The following is a description of a gene set: species: Homo sapiens Enables the transfer of a specific substance or related group of substances from one side of a membrane to the other, up the solute's concentration gradient. The transporter binds the solute and undergoes a series of conformational changes. Transport works equally well in either direction. Human Gene Set: GOMF_ACTIVE_TRANSMEMBRANE_TRANSPORTER_ACTIVITY, and this is the list of marker genes: ABCC12, SLC39A10, SLC12A2, COX4I1, SLCO4A1 (NCBI Gene Id 51737), ABCA3, SLC30A4, ABCC3, CLCN7, SLC8A2, ATP6V1F, MT-ND1, SLCO1C1, SLC29A4, SLC6A6, SLC36A3, SLC9A9, SLC4A8, SLC30A1, SLC25A31, SLC6A15, SLC4A1, ATP6V0D2, SLCO4C1, SLC35B2, CYBRD1, SLC30A9, SLC38A7, SLC8A1, ABCG4, SLC45A2, NDUFS5, SLC25A25, ATP2A1, SLC9B1P1, SLC35A5, SLC10A1, SLC9C2, SLC9B1, TCIRG1, SLC16A13, ATP2A2, LETM1, SLC7A5, NDUFB8, SLC36A1, SLC16A2, SLC18A3, SLC16A4, SLC16A9, SLC18A1, COX7A2L, UQCRC1, SLCO6A1, ABCD2, NDUFA2, MT-ND5, NDUFC1, XPR1, SLC7A11, ABCC5, ATP6V1E2, SLC6A5, SLC45A4, SLC46A2, SLC35A3, ABCC11 (ATP binding cassette subfamily C member 11), SLC17A2, SLC5A10, SLC25A30, SURF1, ATP6V1C2, SLC1A7, TAP1, ATP6V1G1, SLC13A1, SLC29A1, NDUFB1, ABCB11, ABCA4, ABCG1, SLC41A3, SLC25A26, SLC36A2, SLC22A1, SLC35E2A, MT-CO1, SLC4A11, SLC45A3, NDUFV3 (NADH:ubiquinone oxidoreductase subunit V3), UQCRFS1P1 (NCBI Gene Id 7387), SLC15A5, SLC6A18, SLC22A9, ATP6V1G2, SLC7A6, SLC13A3, SLCO1B3, ABCC9, SLC25A21 (solute carrier family 25 member 21), SLC30A5, SLC25A14, SLC20A2, SLC9A6, SLC17A9, SLC25A24, SLC35E2B, SLC25A13, SLC11A2, NDUFA6, SLC7A9, NDUFA8, NDUFS6, SLC35E3, SLC38A3, ABCC10, MT-CO2, SLC4A5, SLC17A7, ATP1A2, SLC6A7, SLC5A8, ABCC4 (ATP binding cassette subfamily C member 4 (PEL blood group)), SLCO2A1, SLC22A7, COX7A1, NDUFV2, TOMM20, SLC39A6, SLC6A13, SLC35C1, ATP2B3, NDUFC2, SLC6A1, ANKH, MFSD2B, SLCO1B3-SLCO1B7, MFSD2A, NDUFB6, CDH17, NDUFB5, SLC25A1, SLC25A11, NDUFA3, TMEM165, TMEM94, ABCB6, ATP6V0C, ATP1A4, SLC22A11, SLC35E1, NDUFB10 (NADH:ubiquinone oxidoreductase subunit B10), ATP2C1, SLC12A6, SLC13A4, SLC1A3 (NCBI Gene Id 6507), CLCN4, SLC6A14, ATP6V0E1, TAP2, ATP6V0A4, SLC17A5, ATP6V0B, MFSD12, SLC26A4, SLC26A2, ABCC8, SLC6A4, SLC25A6, ABCD4, ATP4A, SLC5A6, CYB561A3, SLC17A3, ABCA9, NDUFS1, SLC44A1, SLC13A2, SLC30A8, NDUFA12, SLC10A6, SLC25A4 (solute carrier family 25 member 4), NDUFS8, SLC1A1, COX7B, SLC9A2, SLC38A5, CLCN6, ATP7B, ABCG5, SLC47A2 (NCBI Gene Id 146802), SLC12A9, SLC39A12, SLC35A1, MT-ND6, SLC4A10, SLC9C1, NDUFS7, ATP2B2 (ATPase plasma membrane Ca2+ transporting 2), SLC35A2, SLC16A3, SLC34A1, SLC10A2, ATP6V0D1, SLC10A5, CFTR, SLC5A5, CLCN5, SLC37A3, ABCB10, ATP6V1A, ABCC2, SLC24A2, SLC6A11, SLC28A3, SLC37A4, ABCB4, SLC15A3, SLC6A19, SLC9A5, ATP12A, SLC24A5 (solute carrier family 24 member 5), SLC5A9, SLC5A7, ATP13A2, NNT, SLC38A2, SLC22A4, SLC5A12, ABCA10, UCP2, ATP6V1D, SLC2A9, SLC26A11, ABCA7, SLC25A18, ATP6V1C1, MCU, MTCO2P12, SLC25A22, ATP8A1, SLC11A1, NDUFA9, SLC17A4, KCNJ11, MT-ND4L, ABCB9, NDUFB4, SLC26A1, SLC32A1, NDUFB7, SLC2A10, SLC15A1, SLC6A16, SLC5A4, SLC6A12, SLC25A17, SLC46A1, SLC1A6, RALBP1, SLCO1B7, SLC22A6, SLC16A12, SLC1A4, NDUFA10, ATP6V1G3, SLC17A6, SLC30A10, SLC16A10, SLC22A2, ABCA12, SLC25A12, SLC44A4, SLC24A4, SLC37A1, SLC6A9, ABCG2, SLC46A3, CHP1, ATP2B4 (NCBI Gene Id 54594), SLC25A10, ATP6V1H, CYB561D2, SLC7A13, SLC39A8, SLC12A3, SLC39A14, ABCA2, MT-CYB, SLC24A1, SLC10A3, SLC4A4, MT-ND2, SLC9B2, ATP6V0A1, SLC30A2, SLC7A8, SLC16A14, ABCG8, SLC22A5 (NCBI Gene Id 6584), SLC17A1, SLC6A17, SLC25A15, SLC2A4, SLC8B1, SLCO1A2, SLC25A2, ABCD3, ABCA6, SLC25A20, SLC29A3 (solute carrier family 29 member 3), SLC6A2, SLC5A2, MFSD4B, SLC44A5, NDUFS4, SLCO1B1, SLC35E4, NDUFA1, ABCB1, ABCA8, ABCC6, CTNS, ATP2C2, CYC1, SLCO5A1, SLC35D2, SLC15A2, SLC23A1, SLC5A11, ADAMTS8, SLCO3A1, SLC1A2, ATP4B, ATP13A3, SLC34A2, NDUFB3, SLC12A4 (NCBI Gene Id 6560), MT-ND4, NDUFB2, SLC25A5, SLC26A5 (solute carrier family 26 member 5), SLC47A1, SLC9A1, NDUFS2, ATP5F1B, SLC2A13 (solute carrier family 2 member 13), SLC39A5, SLC26A10P, SLC6A3, COX6B1, NDUFA4, ATP7A, SLC19A1, SLC9A8, SLC9A7, ATP1A3, SLC23A2, UQCRH, SLC24A3 (NCBI Gene Id 96617), SLC22A3, SLC13A5 (solute carrier family 13 member 5, NCBI Gene Id 284111), ABCD1, SLC6A8, COX5A, SLC26A8, SLC39A4, ABCB7, SLC5A1, SLC8A3, SLC9A3, SLC16A1, SLC25A16, SLC45A1, SLC12A8, SLCO2B1, ABCA1, TMEM241, SLC34A3, SLC35D1, SLC35D3, SLC37A2 (NCBI Gene Id 219855), ATP6V0A2, SLC41A1 (solute carrier family 41 member 1), SLC26A3, ATP2B1, UQCR10, SLC16A8, MT-ND3, SLC25A23, SLC25A3, SLC12A7, SLC9A4, SLC17A8, SLC16A7, ABCB5, SLC10A4, SLC12A5, SLC4A2, SLC4A7, SLC6A20, ATP13A4 (NCBI Gene Id 84239), ABCC1, ATP13A1, SLC25A19, MT-CO3, ATP2A3, CLCN3, SLC30A3, SLC44A2, SLC38A4 (NCBI Gene Id 55089), SLC16A11, SLC38A1, SLC28A2, NDUFB9, NDUFV1, SLC22A18, ABCA13, TMCO3, SLC26A9, SLC1A5, COX8A, SLC18B1, NDUFA5, SLC35C2, ATP1B1, SLC30A6 (solute carrier family 30 member 6), ATP6V1E1, ATP6V1B1, ATP1A1, NDUFA7, SLC35B1, SLC26A6, SLC20A1, ATP6V0E2, UQCRFS1, SLC22A8, ATP13A5, NDUFS3, SLC28A1, SLC4A9, SLC10A7, SLC12A1, SLC36A4, GHITM, ABCA5, COX5B, SLC26A7, SLC18A2, MFSD1, SLC15A4 (NCBI Gene Id 121260), KCNJ8, CYB561D1, ATP6V1B2, SLC16A5, SLC4A3, SLC35B3, SLC5A3, ABCB8